The following is a description of a gene set: The methylation of peptidyl-lysine to form peptidyl-N6-methyl-L-lysine. Mouse Gene Set: GOBP_PEPTIDYL_LYSINE_MONOMETHYLATION species: Mus musculus, and this is the list of marker genes: Ehmt1, Setd7, Smyd2, Setd6, Kmt5a, Mettl18, Kmt2a